Given this list of marker genes Ssh2, Fhip2b, Lamc1, Clint1, Sema3e, Snx1, Sema4d, Ogt, Ankrd34a, Fam83g (family with sequence similarity 83, member G), Cplx1, Tmem260, Zfp735, Dlg3, Elmod1, Sertad2, Hecw1, Crebzf, Srd5a1, Krt34 (keratin 34), Slc9a1, Tbx18, Tspan9, Ppbp, Efemp1, Usp15, Lrrc4, Ube2g1, Map1b, Cdk5rap2, Oprk1, Cbx5, Trim37, Hras, Ccnb1ip1, Crispld1, Sec14l2, Vegfc, Nfatc2, Ido2, Dop1a, Luzp1, Susd6, Spin1, Itm2c, Mafb, Larp4b, Nova1, Zfx, Epb41l5, Notch2, Utp15, Golga7b, Hace1, Ndfip1 (NCBI Gene Id 71674), Slc25a27, Abcb9, Ranbp3l, Ush1c, Heyl, Ddi2, Brd1 (NCBI Gene Id 76911), Cdkl3, Zfand5, Tbx20 (NCBI Gene Id 77243), Diras2, Syt4, Rabl2, Rpl22, Ntng1, Marchf2, Rab14, Sntg2, Atf6b, Serpina3j, Slc4a4, Atxn1, Scrt2, Lin28a, Naa50, Defb41, Pdcl2, Pbx1, Zfp523, Cd59a (NCBI Gene Id 98841), Igfl3, Agap1, Nudt3, Tfcp2l1, Cdyl2, Krtap16-1, Cdk6, Mpp3, Max, Itk, Rimkla, Zfp609, Wwtr1, Ccdc153, Becn1, Fech, Sh3kbp1, Cabyr, Usp31, Cxcl15, Tead1, Vdac3, Cdc42, Gtsf1, Tbc1d15, Parva, Ccdc74a, Otop1, Nfat5 (nuclear factor of activated T cells 5), Fhl1, Tnrc6b, Psd3, Cdin1, Pramel3a, Tal1, Cd33, Grm5, Ezh1, Naa15, Rybp, Meis1, Pramel3c, Atf7, Pdk4, Ammecr1l, Epb41l1 (NCBI Gene Id 13821), Rorb, Dcaf5, Pigm, Rsu1, Nlk, Cttnbp2nl, Rps6kc1, Pcdhb4 (protocadherin beta 4), Rcor1, Crb2, Tshz1, Abtb3, Ucp2, Agap3, Pramel3d, Fbln5, Snx12, Hapstr1, Acsm4, Gmfb, Pim3, Slc8a3, Slc8a1, Atp6v1d, Secisbp2, Pramel3b, Cyld, Vamp2, Fbxo11, Pramel3e, here is a description of the gene set: Mouse Gene Set: MIR_6901_5P species: Mus musculus Genes predicted to be targets of miRBase v22 microRNA mmu_miR_6901_5p in miRDB v6.0 with MirTarget v4 prediction scores > 80 (high confidence targets). from publication Chen Y, Wang X (PMID 31504780)